The following is a description of a gene set: species: Homo sapiens Reactome Pathway: Serine metabolism L-Serine is needed in human brain in large amounts as precursor to important biomolecules such as nucleotides, phospholipids and the neurotransmitters glycine and D-serine. The pathway for its synthesis starts with 3-phosphoglycerate and it later needs glutamate as an amination agent. Deficiencies in the participating enzymes lead to severe neurological symptoms that are treatable with serine if treatment starts early (de Koning & Klomp 2004). part of: Metabolism of amino acids and derivatives, and this is the list of marker genes: SERINC3, SERINC2, SRR, SDS, PHGDH, SERINC4, PSPH, PSAT1, SERINC1, SDSL, SERINC5 (serine incorporator 5)